Given this list of marker genes CYBB, CYBA, NCF2, NADK2, NCF1, here is a description of the gene set: Human Gene Set: HP_ABNORMALITY_OF_SUPEROXIDE_METABOLISM Abnormality of superoxide metabolism studied in species Homo sapiens